The following is a description of a gene set: Abnormality of the anterior chamber, which is the space in the eye that is behind the cornea and in front of the iris. Abnormal anterior chamber morphology species: Homo sapiens Human Gene Set: HP_ABNORMAL_ANTERIOR_CHAMBER_MORPHOLOGY, and this is the list of marker genes: CD247, COL8A2, FBN1, IL2RA, PTPN22, COL18A1, EFEMP1, TSPAN12, ATOH7, COLEC10, ANKRD55, SRCAP, PIK3R1, PIGY, MASP1, ASPH, PIGW, COLEC11, PIGO, NDP, FAS, PTPN2, SPATA7, LOXL1, ADAMTS17, IL2RB, LRAT (lecithin retinol acyltransferase), ELMO2, FZD4, FOXE3, MIR204, LARGE1, ZEB1, CYP1B1, LCA5, MYOC, STAT4, HMX1, JAG1, LRP5, ADAMTS10, PXDN (NCBI Gene Id 7837), B3GLCT, VSX1, PIGV, GRHL2, LTBP2, RAB18, PIGL, TEK, FOXC1, MITF, RPE65, ANTXR1, PGAP3, PITX2, PGAP2, OVOL2, CHST14, CHRDL1, PAX6